Given this list of marker genes TGIF1, ECHDC1, DDX3X, ORC1, WSB1, NPPC (natriuretic peptide C), BIN3, BCL10, CCL7, CDC42EP4, TMEM45B, MRPL58, ZFP36, SIL1, TIMP1, TMEM33, FDFT1, KLF6, IER5, FADS2, TFEC (transcription factor EC), LAP3, RND3, FOS, KIF20A, LCLAT1, MARK1, DLD (NCBI Gene Id 2654), ASGR2, TLR2, FRMD6, ST7, UCHL5, HILPDA, LTV1, ICAM1, MYCBPAP, LPAR4, ETS2, KLF2, STAG2 (NCBI Gene Id 10735), SERP1, PPP1R10, KDELR3, KRTAP13-2, CCN1, NDUFC1, SIRT1, CA1, MT2A, IL1A, ACYP1, IL23A, HLA-G, TIPARP, NQO2, RCBTB2, FKBP11, ARHGEF3, CYP1A1, PKP2, THOC7, MST1R, SMARCD3, GALM, FITM1, SERPINF2, CHIC2, USP9Y, SYNGR4, PHPT1, AZI2, SLC4A7, GALK2, ERRFI1, PLA2G4F, SLFN12L, KCNJ9, PLSCR1, PPP1R2P1, TSPO2, PIM3, BCL2L1, IRF4, IHH, GADD45B, TACC2, HSPA5, LYPD1, CHORDC1, EPRS1, WNT2B, GPR3, EREG, PPARG, PTN, IFNB1, GOSR1, ATL2, YARS1, SNAPC3, CLINT1, NDUFB6, MSR1, SYN3, GABRB1, USP16, LCP2, MED21, DUSP14, VDAC3, NLRP3, TNFAIP2, VRK1, ARL6, TIMM17B, CELF4, PRIM2, CEBPD, TBATA, TCN2, ACACB, HDC, NUCB2, NANOS1, ZNF600, TOR2A, MOGAT2, CDK5R1, ALDH7A1, SPATA13, CD84, ATP5PF, MRPL22, PUM3, MAML1, FLVCR1, TM6SF1, LPGAT1, CDKN1A, EPS8L3, DCPS, FMC1, TNFSF10, PPIC, JUNB, IL36G, DHCR7, ZC3H12C, FAM216A, GP9, ATP5F1E, NRL, DUSP8, EIF2B2, HNF4G, ACSS2, AP4M1, ENDOU, CARD10, POLR1E, AKR7A2, SELENOT, MAP3K12, FRMD5, SERTAD2, CSF1, FLNB, NR5A2, HNF1A, CRYBA2, PCBP3, SLBP, IL18BP, ALG14, SH3GLB2 (NCBI Gene Id 56904, SH3 domain containing GRB2 like, endophilin B2), TCEAL8, PARD3B, IL2RB, GLB1, DNAJB9, MAFF, IL13RA2, PTGER4, SELENOK, RNF7, LACTB2, CAMK2A, BCL2L11, RPN1, SMIM30, CXCL6, C1orf54, ARL1, MYO1H, RGS17, AREG, CCNL1, MT1E, ACYP2, here is a description of the gene set: mouse primary BMDCs were stimulated with tlr ligands and gene expression changes were profiled on Affymetrix arrays Human Gene Set: GSE17721_LPS_VS_POLYIC_1H_BMDC_UP from publication Amit I, Garber M, Chevrier N, Leite AP, Donner Y, Eisenhaure T, Guttman M, Grenier JK, Li W, Zuk O, Schubert LA, Birditt B, Shay T, Goren A, Zhang X, Smith Z, Deering R, McDonald RC, Cabili M, Bernstein BE, Rinn JL, Meissner A, Root DE, Hacohen N, Regev A (PMID 19729616) Genes up-regulated in comparison of dendritic cells (DC) stimulated with LPS (TLR4 agonist) at 1 h versus DC cells stimulated with poly(I:C) (TLR3 agonist) at 1 h. studied in species Homo sapiens